The following is a description of a gene set: from publication Chen Y, Wang X (PMID 31504780) Mouse Gene Set: MIR_410_5P Genes predicted to be targets of miRBase v22 microRNA mmu_miR_410_5p in miRDB v6.0 with MirTarget v4 prediction scores > 80 (high confidence targets). species: Mus musculus, and this is the list of marker genes: Patl1, Lrrc20, Ptbp2, Postn, Npas3, Trpc6, Pde1a, Fmn2, Clca2, Tnfsf10, Nhlh2, Rsf1, Taf5, Clip4, Il12b, Lman1 (NCBI Gene Id 70361), Chp1, Pik3r3, Ndufab1, Camk2b, Plod1, Olfml3, Ptpn13, Rnf24, Alox8, Adcyap1, P3h1, Ubtf, Hspd1, Pigz, Pdgfc, Lrrc8a, Dst, Npy1r, Itga6, Rora, Il1a, Tspan11, Clec7a, Rad23b